Given this list of marker genes PEG10, CLDN16, GJB4, EPHB2, GJB2, GJA3, MIP, GJA8, ARC, GJB6, here is a description of the gene set: species: Homo sapiens The movement of substances between cells. Human Gene Set: GOBP_INTERCELLULAR_TRANSPORT